Given this list of marker genes NDE1, NUMBL, HHIP, OTP, ARHGEF2, CX3CR1, NUMB, FZD9, FOXG1, RACGAP1, SOX10, LEF1, PROX1, ITGB1, SKOR2, PLXNB2, DAGLA, SOX5, KCTD11, ACSL6, GLI3, DRD2, CDON, ID4, NOTCH1, NBN, TGFB1 (transforming growth factor beta 1), LHX5, KCNA1, SHH, FZD3, EML1, PTN, WDR62, ASPM, SMARCD3 (SWI/SNF related, matrix associated, actin dependent regulator of chromatin, subfamily d, member 3), KDM1A, AKNA, LRRK2, DOCK7, TP53, VSX2, VEGFA, MIR137, KIFAP3, ASCL1, WNT3A, DMRTA2, CX3CL1, PAFAH1B1, NR2E1, DISC1, TAFA1, BTG2, FRS2, RAB10, FGF13 (NCBI Gene Id 730528), DAGLB, FGFR1, ARTN, FGF2, SIX3, TEAD3, DCT, NEUROD4, VEGFC, SMO, GATA2, CTNNB1, PAX6, NF1, HIF1A, FGFR2, ZNF335, VAX1, CTNNA1, here is a description of the gene set: Human Gene Set: GOBP_NEUROBLAST_PROLIFERATION species: Homo sapiens The expansion of a neuroblast population by cell division. A neuroblast is any cell that will divide and give rise to a neuron.